The following is a description of a gene set: Mouse Gene Set: GOBP_CHONDROITIN_SULFATE_PROTEOGLYCAN_CATABOLIC_PROCESS species: Mus musculus The chemical reactions and pathways resulting in the breakdown of chondroitin sulfate proteoglycans, which consist of a core protein linked to a chondroitin sulfate glycosaminoglycan. The chondroitin sulfate chain is composed of the repeating disaccharide unit beta-(1,4)-D-glucuronic acid-beta-(1,3)-N-acetyl-D-galactosamine, the latter of which can be O-sulfated., and this is the list of marker genes: Galns, Hyal4, Hyal1, Arsb, Gusb, Hexb